Given this list of marker genes BMP4, FGF2, BMP2 (bone morphogenetic protein 2), RPTOR, SERPINE1, IPO7, CTNNB1, LEF1, here is a description of the gene set: Any process that activates or increases the frequency, rate or extent of neuroepithelial cell differentiation. Human Gene Set: GOBP_POSITIVE_REGULATION_OF_NEUROEPITHELIAL_CELL_DIFFERENTIATION species: Homo sapiens